The following is a description of a gene set: Human Gene Set: GOBP_POSITIVE_REGULATION_OF_TRANSCRIPTION_BY_RNA_POLYMERASE_II species: Homo sapiens Any process that activates or increases the frequency, rate or extent of transcription from an RNA polymerase II promoter., and this is the list of marker genes: ZNF750, MLX, TAF5, KLF7, ERCC1, DOT1L, BSX, NFATC1, TAF4B, MRTFA, NCK2, TNFSF11, BCL11A, GLI2, USF1, AAMDC, SHOX, ZNF407, FGF10, NHLH1, POU2F3, GRHL2, ETV5, BMP5, PAX3, WNT5A, F2RL1, ETV1, TET2, HOXA13 (NCBI Gene Id 3209), ARID3C, ALX4, ACVR1, PF4, PKM, MRTFB, NFYC, CSF3, KLF2 (NCBI Gene Id 51713), EFCAB7, MCIDAS, ASH1L, INO80, IL1B, MED28, SOX4, IL4I1, IFT74, CDX2, HOXC13, TCEA1, CGA, GRIN1, UBE2E1, GREM1, CDX4, SMAD2, PPARGC1B (NCBI Gene Id 153346), HGF, TAF7, OVOL2, ABLIM3, ADCYAP1, LMO3 (NCBI Gene Id 55885), HMGB1 (high mobility group box 1), PLAGL2, TOX3, AKIRIN1, MYBBP1A, RFX7, ARRB1, TMPRSS6, ZNF335, PER1, APBB1, HES5, POU4F1, PARK7, SPIC, ELF1 (NCBI Gene Id 1997), GLI3, FGF1, KLF4, HSF2, ANKRD23, IL33, HOXB9, ATOH1, LRP5, ETV4, IRF1, FZD5, MEIS3P1, ACTN4, MAVS, VGLL2, NKX2-3, MED27, DRD2 (dopamine receptor D2), ZNF563, DLX5, HCFC1, ATF4, RPS6KA1, TBL1XR1 (NCBI Gene Id 81612), SOX3, TAF13, PCGF5, XBP1, ATXN1, TBR1, ZFAT, RFXANK, NFYB, NEUROG3, MED4, ZNHIT1, STAT5A, EBF4, MED1, PAX8, STK16, CCNT2, EIF4A1, CHD7, TAF4, PARP1, VEGFA, JAG1, PRDM16, PPP1R12A, RBMX, LPIN2, OSM, ZFHX3, NFE4, NEUROG2, XCL1, TCF7L2, CAPRIN2, NR1H3, TBX2, RIGI, TCF3, TCF4, ZFPM1 (zinc finger protein, FOG family member 1), PLAGL1, ZBTB49, MYO1C, MEIS1, E2F7, GLIS2, IRX4, NEUROD6, TGFB3, RPRD1B, PLSCR1, SOX2, NEUROD4, PDX1, AHI1, GATA4, BAZ1B, HEY2, ELL2, SERPINF2, ARID5A, CSRNP1, NKX2-8, ZNF507, LHX4, BCAS3, SMAD9, IL25, MED21, FOXN4, HYAL2, MIXL1, ZNF597, GDNF, FUBP3, BARHL2, E2F2, IGF2, HMGA1, FOXR1, OSR2, DDX3X, WASL, PRDM2, EAF2, NFIB, SETSIP, DCN, BHLHA15, LDB2, RNF40, HNF1A, MYT1L, SUPT5H, IRF5, USF2, CHUK, RFX6, KDM1A, TBX5, NFKBIZ, GPS2, IRF6, OLIG3, MEF2A, CTCF, NLRP3, THRB, DCAF6, SFPQ, PRKDC (protein kinase, DNA-activated, catalytic subunit), GABPA, MEPCE, WBP2, NELFA, ARNT2, POU4F3 (NCBI Gene Id 5459), MED31, PYGO1, ZNF711, PUS1, NKX6-1, ABHD14B, FLI1, HOXD8, MYOCD, NOTCH4, MYF5, PRPF6, PLAG1, GLI1, NCK1, VDR, E2F4, MEF2B, HCLS1, MECP2, PSIP1, TFDP2, FOXD3, BACH1, ESRRB, SFRP2, ATF3, RNF10, ABLIM1, KMT2C, RLF, PWWP2A, MEF2D, TOP2A, TP73, MZF1, HIF1A, TFCP2L1, IKZF4, SMO, WWP2, NRL, EGLN1, PAX6, TAF3, PKNOX1, PIN1, SOX1, SIX3, RUNX1, ID4, LPIN1, ZNF410, TAL1, ZNF550, CEBPD, CEBPG, VEZF1, TOX4, CDK5RAP3, PTF1A, GATA1, HOXC10, H2AZ1, ASXL3, HELT, IL17F, MED12L, COPS5, GAL, ALX1, TFE3, AP3B1, CRTC1, LHX3, DEK, BCLAF3, EYA1, TGFB1, KLF12, ESRRG, IRF9, PCBP1, STAT3, SMARCB1, MAMSTR, ZBTB7C, MESP1, HOXB1, MECOM, MED6, CSRNP2, NFE2L2, RIT2, AGO1, CDH13 (NCBI Gene Id 1012), ZNF24, SMAD4 (NCBI Gene Id 4089), TTC5 (NCBI Gene Id 91875), SOX9, RPS6KA5 (ribosomal protein S6 kinase A5), HNRNPK, ONECUT3, RBM14, NCOA6, STAT6, GRHL1, TAF11, FOXO1, ZNF485, TNIP2, NKX2-1, TAF2, GTF2A2 (NCBI Gene Id 2958), MYSM1 (Myb like, SWIRM and MPN domains 1), TP63, NCOA3, CEBPA, NELFE, TXK, PAX5, RBM15, DDX41, AUTS2, WAS, AGRN, TCERG1, MED12, ERCC6, LDB1, NR1D1, ATF1, ZBED1, CD81, MED20, IL23A, SPX, SETX, TEAD4, PITX1, TRERF1, RARG, EVX1, PAXIP1, IRX3, LEO1, BORCS8-MEF2B, MYF6, ZNF268, BARX2, ST18, ATOH8, ARX, GABPB2, LIF, SETD4, MED17, YY1, IFNG, PROP1, SUPT4H1, NR4A1, ZBTB16, FZD4, STAT4, SP7, ELL3, ZBED4, PRDM4, COQ7, TOX2, GSK3A, SIX5, TAF9, BCL3, EIF5A, MED18 (NCBI Gene Id 54797), GSX1, MKRN2, NFE2L1, HTATIP2 (NCBI Gene Id 10553), MYOD1, NFIA, EPAS1, SOX15 (SRY-box transcription factor 15), PHF8, SRF, E2F3, MED22, DMRT1, ANXA2, SOX7, MED7, FOXO4, THRA, LPIN3, MICAL2, ACTR2, MTF1, NEUROG1 (NCBI Gene Id 4762), ATMIN, LMO2, IRF7, NPAS4, MEOX1, TMF1, EZH1, NR2C2, ARMCX3, CCNT1, HSF1, SOX11, TCF12, KANSL3 (NCBI Gene Id 55683), BMPR1A, HLTF, HOXB3, BATF, NCOA1, NPAT, PLA2G1B, DAB2, SMAD1, PSMC3, CASK, SOX18, NFATC2, MOSPD1, GCM2, SLC38A3, CTCFL, PPARD, PPP1R10, HDAC3, NOG, BHLHE23, POMC, RAF1, CHP2, FHOD1, MED8, PHIP, SUB1, PRRX1, ZNF219, TFAP2C, RARB, NLRC5, NODAL, IL17A, SIX2 (SIX homeobox 2), ATF6, GTF2F2, ZMYND8, POU4F2, YWHAB, KLF5, WNT2, ELK1 (ETS transcription factor ELK1), KLF14, NKX2-6, PPP3CB, NDP, HNF4G, PPARGC1A, GBX2, MAPKAPK5, WWOX, GALR2, SPI1, NR2E3, MLLT10, GRHL3, POU3F2, MTA2, ADRB2, ONECUT2, SP3, ZBTB38, OGT, CDON, FGFR2, THRAP3, EAPP, HSPA5, MSX1, MET, ZMIZ1, EP300, YBX1, NFKB1, ZNF780B, DMRT2, JUNB, FIZ1, AKAP8L, GLIS1, TEAD3, PPP2R5B, NFATC4, CDK8, ONECUT1, MED19, ZBED3, TNIP1, RPS6KA4, IER2, SMARCA4, HOXB2, ZMIZ2, SALL1, FOXN1, ZEB2, ETS2, TBX1, TLR7, NCOA2, CSRNP3, PTBP1, NR1H2, ZIC1, HELZ2, TAF12, ZNF462, WNT7A, PFKM, ASXL2, TLX1, SQSTM1, LHX2, TCF21, ZNF300, MED26, NCOA7, HDAC1, BRCA1, STAT2, TFEC, NFKB2, PTPRN, PLPP3, KMT2D, APP, PRKD1, GLMP, OSR1, P2RY1 (purinergic receptor P2Y1), NHLH2 (NCBI Gene Id 90888), CITED1, EDN1, CREBBP, ZNF609, BARHL1, IKZF3 (NCBI Gene Id 22806), SRY, CDK12, LMO4, ZNF292, CCNC, MEF2C, TCF15, KAT6B, AKNA, NKX2-2, RELA, HOXD10, NOTCH2, SCX, BMP6, NPM1, CNOT7, PITX3, IL18, MBTPS2, PURB, CDKN2A, CRTC3, HRAS, TWIST1, NRIP1 (nuclear receptor interacting protein 1), MYBL1, CRLF3, NOTCH1, UBP1, SSBP2, POU2F1, TAF10, CDC5L, SLC30A9, CCDC62, PPARG, TNFSF8, PSMC6, ZNF593, SOX14, BMP2, RGMA, ZNF746, HOXB7, CREB3, UCN, SMARCAD1, ATOH7, TAF6, CAND1, ZFY, MED9, TBX3, RXRA, PRKN, RIPK1, BMP4, DVL1, DUX4, POU5F1, RAX, MLLT6, CDX1, TP53BP1, ZEB1, ZNF175, TFAP2D, MED25, IRF3, TBK1, RB1, NACA, MYC, SF3B1, FIGLA, MAP2K1, RORB, ARID3A, BMPR2, TNKS, IL4, RFXAP, SSBP3, JPX, GTF2F1, STAT5B, CELA1, FOXH1, JUND, TLR9, IL2, ATF7, ZNF329, POU2F2, MAML1, ISL1, FOXC2 (NCBI Gene Id 50824), POU2AF1, RORA, HJV, PTMS, DLX3, EHF, ZFP64, NR2E1, GTF2I, ZNF580, YY2, LEF1, ADIRF, PPP1CA, BMP3, BRD3, E2F1, MED13, HLF, SS18L1, ETV6, ZNF263, TLR4, NR1D2, SSBP4, MCRS1 (NCBI Gene Id 10445), NDN, ASCL2, HIPK2, ATF6B, THAP11, HOXA4, GATA5, NOD2, IL11, HAND2, PKD1, MAPK7, THAP3, FOXI1, PRDM5, MYOG, CTR9, TBX19, HOXB5, HOXB4, ZIC3, UBE3A, ABRA, PPARA, ARF4, PID1, METTL23, JMJD6, SP1, NR1I3, POGZ, MED15, KLF13, ZSCAN21, SUMO2 (small ubiquitin like modifier 2), GCM1, SKAP1, MAFF, TFR2, CAMK1 (calcium/calmodulin dependent protein kinase I), EPCAM, MMP12, NEUROD1, SOX21, WWTR1, ELF5, NCBP1, SBNO2, SERTAD1, RFX4, LUM, MYD88, HAX1, HDAC2, NFATC3, OGG1, MEN1, CDC73, TFDP1, HDGF, TAF8, CXCL10, BCL9L, PTEN, ZC3H12A, EGR3, HNRNPD, KDM3A, GPBP1, PTMA, XPA, NR4A2, GATA3, ARID4B, MLXIPL, FEZF2, DDX17, GFI1B, DLX2, SKI, RIPK2, HNF1B, HDAC5, PPP3CA, CAVIN4, DAB2IP, RRP1B, HHEX, KAT2B, CHD8, ZNF143, UHRF1, SENP2, FOXA2, EGFR, HINFP, ETV2, SENP1, NEUROD2 (NCBI Gene Id 4761), TFAP2A, TET3, ACVR2A, REST, DVL3 (dishevelled segment polarity protein 3), ELK4, HES6, ZNF76, OTX1, KLF10, EBF2, PROX1, RGCC, NIPBL, PAGR1, HOXA9, PAX7, NKX2-5, APBB2, TEAD2, KAT2A, FZD1, SMARCA2, JAK2, MEIS2, ASCL1 (NCBI Gene Id 429), FOXL2, ZSCAN2, GLIS3, APEX1, HMGB2, ZNF395, CTBP2, SIRT2, SOX8, UTF1, CD40, CREB3L3, HNF4A, IGF1, GATA6, MC1R, TBX6, CLOCK, HNRNPU, JUN (Jun proto-oncogene, AP-1 transcription factor subunit), POU1F1 (NCBI Gene Id 5449), DBP, AKIRIN2, ZNF212, TLX2, FADD, WNT10B, MAFA, TNF, XRCC6, MACC1, BMAL2, RUVBL2, CREB3L4, ESR2, ING3, USF3, IFNB1, RNASEL, HOXD9, HEY1, S100A10, PGR, SALL2, DVL2, FOXA1, DDN, IL6, TFAP2E, ATF5, HIVEP1, TCF20, LMX1B, YAP1, INHBA, LRP6, AIRE, CARF, FOS, FOXM1, EEF1D, LARP7, HOXC4, ZNF513, RFX3, TNFRSF1A, MED16, ZBTB18, SHH, MED23, ATRX, TFAP4, MAX, SIRT1, TLR3, ASCL3, SMARCA5, MED11, ZNF827, MED13L, MED29, MYDGF, MED10, KDM6B, MED30, AR, RFX2, NUFIP1 (nuclear FMR1 interacting protein 1), SP100, SLC11A1, DDRGK1, NFATC2IP, KLF15, PITX2, MAML3, CASZ1, BEX1, HAND1, NUCKS1, SETD3, FOXJ2, ARNT, MEIS3, NCBP2, PAX9, MAML2, EGR4, ASXL1, CDK7, FOXA3, FOXJ1, HDAC4, IL10, CD200, ISL2, CCN1, FBLN5, ITGA8, LITAF, GPER1, CCNK, RUNX2 (RUNX family transcription factor 2), TFAP2B, CREB3L1, MAPK14, NOTCH3, DLL1, E4F1, CNBP, IRX6, FOXK2, BCL9, PPRC1, FOSL2, IHH, CASC11, STING1, NR5A1, SPAG8, ETS1, ELF4, BPTF, RAX2, CCPG1, HOXD13, FSHB (follicle stimulating hormone subunit beta), BCL2L12, MYCN, CAMTA1, SIX1, CDK9, ERG, MAPK3, MITF, FOXO3, WNT3A, PCK1, NR3C1, NAMPT, NKRF, NR1I2, TRIAP1, SPIB, PKD2, AHR, SMYD3, PAF1, NFYA, MLIP, EOMES, BHLHE22, CREBZF, FOXF2, IKBKG, DDIT3 (DNA damage inducible transcript 3), DDX21, SLC9A1 (solute carrier family 9 member A1), PAXBP1, DHX9, E2F8, HMGA2, HOXD3, SNW1, TBL1X, NCL (nucleolin, NCBI Gene Id 4691), IRF2BPL, CALCOCO1, FOXF1, WDR82, AKT1, HOXC11, HEXB, KPNA6, NR1H4, NFIC, LILRB1, ATF2, PBX1, CREBRF, DHX36 (NCBI Gene Id 96337), CXCR3, PWWP2B, AGO2, IL13, CEBPB, STRN3, FGF4, ZNF71, NFAT5, FHL5, NR4A3, ABL1, RBPJ, IRF4, PINK1, PKP1, EGR1, TBX20, CX3CL1, NPNT, BTBD18, FOXJ3, RELB, IL1A, KAT5, NR2F1, HOXD4, TEF, RBPJL, PHOX2A, CSRP3, NR2F2, MYBL2, TP53, HES1, ATM, SOX17, ZNF148, MYB, S1PR1, TBXT, BCL11B, ZBTB7B, NME2, CREM, FSTL3, ACTR3, PIK3R1, HOXA2, CHD6, TEAD1, PBX3, ESR1, SREBF2, SREBF1, KAT7 (NCBI Gene Id 63437), MAPK15 (NCBI Gene Id 225689), IRF8, CYTL1, AP3D1 (adaptor related protein complex 3 subunit delta 1), PAX2, GABPB1, SS18, RXRG, EN1, SMARCC1, ITGB1BP1, BCLAF1, POU3F3, OLIG2, ACVRL1, ZNF639, ZFX, TFEB, RARA, PEG3, OLIG1, MUC1, GALR3, SALL4 (NCBI Gene Id 57167), BMP7, BMAL1, MAFB, GTF2A1, MED14, RHOQ, MSGN1, ARHGEF2, TAF1, CAMTA2, CRTC2, REL, PRDM15, RNF20, TBX21, MIR9-1HG, DLX1, PBX2, ENG, BRD4, ZNF728, ELK3, STAT1, NKX3-1, ARID3B, SATB2, ZNF616, TFCP2, KAT8, CRX, RREB1, LMX1A (LIM homeobox transcription factor 1 alpha), CEBPZ, CBFB, IER5, NFIX, ZBTB17, ELF3, USP16, PRDM10, CTNNB1, ZNF784, BMPR1B, NR6A1, GDF2, ECD (ecdysoneless cell cycle regulator), RPS6KA3, IRF2, ZNF431, MLXIP, ZFPM2, WNT1, ITGA6, FGF2 (NCBI Gene Id 2247), ZNF776, SPDEF, WNT8A, EGR2, TBP, IFI16, FOXC1, MAP2K5, RFX5, NANOG, YES1, NOS1, LMO7, FOXD2, IKBKB, RNF4, MAFG, PLAC8, CITED2, ELL, CHCHD2, FOXP3, EXOSC9, SOX12, KDM4C, RTRAF (NCBI Gene Id 51637), ARID4A, HOXA5, RXRB, HOXA1, PIK3R2, KLF6, SMARCA1 (SWI/SNF related, matrix associated, actin dependent regulator of chromatin, subfamily a, member 1), CIITA, NKX6-3, NRF1, CKAP2, SIX4, VSX2, CREB3L2, SOX10, GALR1 (galanin receptor 1), GATA2, SLC40A1, FOSB, CDK13, SOX30, SMAD3, PTH (NCBI Gene Id 5741), PHOX2B, NR5A2, TLR2, VENTX, EN2, HOXA7, HEYL, HOXA10, OTX2, SMAD5 (SMAD family member 5), ZNF304, WT1, ZGLP1, MEOX2, TET1, ESRRA, EPC1, PELP1, MED24, KMT2A, GMEB1, BRD8, CD28, TOX, ZNF131, CREB1, FOXD1, CEBPE (NCBI Gene Id 1053), JUP, MAF, TRAF6, ZNF345 (NCBI Gene Id 25850), LMO1, PTOV1, FEV, PRKD2, NFKBIA, PPP3R1, IL26